The following is a description of a gene set: Mouse Gene Set: GOBP_POSITIVE_REGULATION_OF_SYNCYTIUM_FORMATION_BY_PLASMA_MEMBRANE_FUSION species: Mus musculus Any process that increases the frequency, rate or extent of the formation of a syncytium, a mass of cytoplasm containing several nuclei enclosed within a single plasma membrane, by the fusion of the plasma membranes of two or more individual cells., and this is the list of marker genes: Rapgef3, Gcm1, Tnfsf14, Capn2, Ehd1, Ccl8, Adgrb1, Dcstamp, Ocstamp, Tyrobp, Trem2 (triggering receptor expressed on myeloid cells 2), Scgb3a1, Cd53, Ehd2, Gdf15, Nfatc2, Il4, Adam9, Myod1, Flot1, Camk1, Il4ra, Mapk14, Cxcl9, Ripor2, Flt3l, Cxcl12